Given this list of marker genes TRNT1, UROS, TET2, KCNE5, TMPRSS6, VPS13A (vacuolar protein sorting 13 homolog A), SLC2A1, MTTP, TOR1A, PKLR, SAR1B, SC5D, CYP4F22, GYPC, APOB, CLPB, EPB41, CFH, HBB, ABCB6, CA2, AMMECR1, KLF1, PANK2, ACSL4, RACGAP1, SLC4A1, PIGA, G6PD, GP1BA, CFHR3, CFHR1, RHD, SLC19A1, C1GALT1C1, UMPS, PIEZO1, ABCG8, ANK1, CUBN, SPTA1 (NCBI Gene Id 6708), RHAG, ABCG5, CDAN1, AMN, MPL, ABCB7, STEAP3, JAK2, RHCE, XK, CDIN1, SPTB, CALR, EPB42, CAD, CASK, KIF23, ADAMTS13, NHLRC2, KCNN4, CRIPT, MPIG6B (NCBI Gene Id 80739), GATA1, here is a description of the gene set: Poikilocytosis species: Homo sapiens Human Gene Set: HP_POIKILOCYTOSIS The presence of abnormally shaped erythrocytes.